Given this list of marker genes FSD2, OSR1, SMPX, ZFYVE19, CLDN19, SHF (NCBI Gene Id 90525), HS3ST3B1, JSRP1, HOXB1, GIMAP6, ACYP1, NLRC5, RAB6B, KLB, TMEM63C, CMA1, IL25, KCNK3, RCN3, TRAPPC6A, COL15A1, CSRP1, UBE2S, RCAN1, CTHRC1, RPL8, STOML2, FZD4, HAPLN2, MIR652, GIMAP8, EGFL6, TGM3, MIR301B, USHBP1, RPLP0, DCLRE1A, KATNAL1, FAM110B, PARP3, CTSZ, COLEC10, GCM1, DIP2C (disco interacting protein 2 homolog C), BMF, CNPY1, GUCA1B (guanylate cyclase activator 1B), ZMYND10, RPL18, EPS8L1, WSCD1, FAM110A, HSH2D, CERK, MBD3L2 (NCBI Gene Id 195825), ACADL, CTNNA2 (catenin alpha 2), HPCAL1, CELSR3, BTG2, RELL1, RPS15A, MYH11 (myosin heavy chain 11), IRAG1, NRXN1, PAX7, RUNDC3B, ATP6V1D (ATPase H+ transporting V1 subunit D), GRHL3, C3, CPM, PPP1R3E, EREG, SLC29A2, GPR55, SIRPA, ABHD14A, TIMP3, GNGT1, CALD1, POLD4, SFXN2, DNASE1L3, BAHCC1, ATP8B4, RBSN, DCBLD2, ESYT3, CPSF3, NDUFA12, CAPG, BRMS1L, CKB, COL11A1, GIPR, FRMPD1, PGAP2, GIPC3, TRAPPC3L, MDH2, H2BC26, PRSS41, KDM8, AIFM2, SPECC1, IL20, ITIH2, DSCAM, CCS (copper chaperone for superoxide dismutase), BANK1, GIMAP4, DNASE1L2, KIF27, GPR37L1, RPL26, MIR23B, CLU, RPL34, CEP131, FBH1, COL12A1, S100A11, SPRY4, BAIAP3, RNF144A, TFF2, DPY19L1, SYNPO, CELSR1, here is a description of the gene set: Tumor necrosis factor-associated factors 2 and 3 (TRAF2 and TRAF3) were shown to function in a co-operative and non-redundant manner to suppress nuclear factor-κB2 (NF-κB2) activation, gene expression and survival in mature B cells. In the absence of this suppressive activity, B cells developed independently of the obligatory B cell survival factor, BAFF (B cell activating factor of the tumor necrosis factor family). This constitutive, lineage-specific suppression of B cell survival by TRAF2 and TRAF3 determines the requirement for BAFF to sustain B cell development in vivo. We wished to investigate the effect on gene expression in B cells which lacked the negative regulators TRAF2 and TRAF3, and hence had hyperactive NF-kB2 signalling. As Baff-tg mice display a similar phenotype, and have a genetic modification which acts in the same pathway, yet further up, than TRAF2 and TRAF3, we wished to compare and contrast Baff-tg B cells with TRAF2 and TRAF3 deficient B cells. This analysis should identify genes that are important in B cell survival. Genes down-regulated in wildtype B cells versus BAFF-transgenic (over-express TNFSF13B) B cells from lymph node. species: Homo sapiens from publication Gardam S, Sierro F, Basten A, Mackay F, Brink R (PMID 18313334) Human Gene Set: GSE10422_WT_VS_BAFF_TRANSGENIC_LN_BCELL_DN